Given this list of marker genes PRPS1, PRPS2, PRPSAP2, PRPS1L1, PRPSAP1, here is a description of the gene set: Human Gene Set: GOBP_5_PHOSPHORIBOSE_1_DIPHOSPHATE_METABOLIC_PROCESS The chemical reactions and pathways involving 5-phosphoribose 1-diphosphate, also known as 5-phosphoribosyl-1-pyrophosphate. species: Homo sapiens